The following is a description of a gene set: species: Homo sapiens from publication Smid M, Wang Y, Zhang Y, Sieuwerts AM, Yu J, Klijn JG, Foekens JA, Martens JW (PMID 18451135) Genes up-regulated in lung relapse of breast cancer. Human Gene Set: SMID_BREAST_CANCER_RELAPSE_IN_LUNG_UP We explored whether the five previously reported molecular subtypes in breast cancer show a preference for organ-specific relapse and searched for molecular pathways involved. The intrinsic gene list describing the subtypes was used to classify 344 primary breast tumors of lymph node-negative patients. Fisher exact tests were used to determine the association between a tumor subtype and a particular site of distant relapse in these patients who only received local treatment. Modulated genes and pathways were identified in the various groups using Significance Analysis of Microarrays and Global Testing. Bone relapse patients were most abundant in the luminal subtypes but were found less than expected in the basal subtype. The reverse was true for lung and brain relapse patients with the remark that absence of lung relapse was luminal A specific. Finally, a pleura relapse, although rare, was found almost exclusively in both luminal subtypes. Many differentially expressed genes were identified, of which several were in common in a subtype and the site to which the subtype preferentially relapsed. WNT signaling was up-regulated in the basal subtype and in brain-specific relapse, and down-modulated in the luminal B subtype and in bone-specific relapse. Focal adhesion was found up-regulated in the luminal A subtype but down-regulated in lung relapse. The five major molecular subtypes in breast cancer are evidently different with regard to their ability to metastasize to distant organ(s), and share biological features and pathways with their preferred distant metastatic site., and this is the list of marker genes: PSPH, RYR1, KLK7, KPNA4, UCHL1, KLK6, ADD2, FOXD1, MMP14, SLC7A5, PRAME, NMU, CLIC4, COL2A1, CTSV, ANP32E, TTYH1, HAPLN1, MUC16, CSPG4, TNNI2, KRT17